The following is a description of a gene set: Mouse Gene Set: GOBP_REGULATION_OF_MITOTIC_SISTER_CHROMATID_SEGREGATION species: Mus musculus Any process that modulates the frequency, rate or extent of sister chromatid segregation during mitosis., and this is the list of marker genes: Arhgap33os, Zfp207, Ccnb1, Anapc15, Gen1, Hnrnpu, Ik, Pcid2, Rad21, Prpf4b, Tex14, Cenpe, Apc, Ndc80, Ska1, Cdca8 (NCBI Gene Id 68105, cell division cycle associated 8), Birc5, Fbxo5, Bub1b, Mad2l1bp, Aurkb, Dusp1, Cdk5rap2, Ccnb1-ps, Zwilch, Anapc15-ps, Ttk, Lcmt1, Incenp, Spdl1, Bub3, Kat2b, Mad1l1, Ska3, Tpr, Dync1li1 (dynein cytoplasmic 1 light intermediate chain 1), Xrcc3, Spc24, Bub1, Knl1, Nuf2, Becn1, Mad2l1, Kat5, Cdc20, Kntc1, Usp44, Haspin, Prap1, Spc25, Khdc3 (KH domain containing 3, subcortical maternal complex member), Plk1, Sirt1, Atm, Trip13, Cdk1, Numa1, Psmg2, Zw10, Klhl22, Zwint, Cep192 (centrosomal protein 192)